The following is a description of a gene set: studied in species Mus musculus This event has been computationally inferred from an event that has been demonstrated in another species.<p>The inference is based on the homology mapping from PANTHER. Briefly, reactions for which all involved PhysicalEntities (in input, output and catalyst) have a mapped orthologue/paralogue (for complexes at least 75% of components must have a mapping) are inferred to the other species. Reactome Pathway: TP53 Regulates Transcription of DNA Repair Genes electronically inferred by orthology from the curated human pathway part of: Transcriptional Regulation by TP53, and this is the list of marker genes: Polr2l, Supt16, Cdk13, Supt4a (NCBI Gene Id 20922), Gtf2h4, Polr2e, Ctdp1, Ercc2, Gtf2f1, Nelfa, Tcea1, Ccnh, Gtf2f2, Polr2f, Polr2b, Polr2a, Cdk12, Ercc3, Polr2k, Polr2c, Gtf2h2, Polr2i, Supt5, Nelfe